The following is a description of a gene set: Human Gene Set: GAUCHER_PBMC_YF_VAX_STAMARIL_UNKNOWN_AGE_60DY_DN Genes down-regulated in peripheral blood mononuclear cell 60d vs 0d in unknown after exposure to YF-Vax/Stamaril, time point 60D from publication Gaucher D, Therrien R, Kettaf N, Angermann BR, Boucher G, Filali-Mouhim A, Moser JM, Mehta RS, Drake DR 3rd, Castro E, Akondy R, Rinfret A, Yassine-Diab B, Said EA, Chouikh Y, Cameron MJ, Clum R, Kelvin D, Somogyi R, Greller LD, Balderas RS, Wilkinson P, Pantaleo G, Tartaglia J, Haddad EK, Sékaly RP (PMID 19047440) Correlates of immune-mediated protection to most viral and cancer vaccines are still unknown. This impedes the development of novel vaccines to incurable diseases such as HIV and cancer. In this study, we have used functional genomics and polychromatic flow cytometry to define the signature of the immune response to the yellow fever (YF) vaccine 17D (YF17D) in a cohort of 40 volunteers followed for up to 1 yr after vaccination. We show that immunization with YF17D leads to an integrated immune response that includes several effector arms of innate immunity, including complement, the inflammasome, and interferons, as well as adaptive immunity as shown by an early T cell response followed by a brisk and variable B cell response. Development of these responses is preceded, as demonstrated in three independent vaccination trials and in a novel in vitro system of primary immune responses (modular immune in vitro construct system), by the coordinated up-regulation of transcripts for specific transcription factors, including STAT1, IRF7, and ETS2, which are upstream of the different effector arms of the immune response. These results clearly show that the immune response to a strong vaccine is preceded by coordinated induction of master transcription factors that lead to the development of a broad, polyfunctional, and persistent immune response that integrates all effector cells of the immune system. species: Homo sapiens, and this is the list of marker genes: HAGH, MARCHF2, GUK1, OR2T35, ADIPOR1, PDZK1IP1, DNAJB2, GUCD1, PRDX2, ROPN1B, PRDX5, YBX3, MYL4, SERF2, DPM2, PLEK2, CDC14B, DMTN, FIS1, UBXN6, MBNL3, STMN3, SESN3, FBXO7, TGM2, TSPAN5, GYPC, TPRA1, DCAF6 (DDB1 and CUL4 associated factor 6), SRRD, HBQ1, PHOSPHO1, FKBP8 (FKBP prolyl isomerase 8), ST6GALNAC4